The following is a description of a gene set: Absence (due to failure to form) or underdevelopment of the extremities. Human Gene Set: HP_APLASIA_HYPOPLASIA_OF_THE_EXTREMITIES studied in species Homo sapiens Aplasia/hypoplasia of the extremities, and this is the list of marker genes: POR, DACT1, KDM6A, WRN (NCBI Gene Id 7486), ARX, CRKL, PRKG2, KAT6B, SMARCB1, FBXO11, CANT1, HOXA13, BMP2, DMXL2, MGP, COG1, FANCE, ERCC4, SLC35C1, GRM7, RIPK4, GJB6, KDM5C, MTHFS, IFT43, EIF2AK3, PORCN, CAMK2G, TRAPPC2, DPH1, RB1, NGLY1, MED12, SMARCD1, STAMBP, RYR3, SLC31A1, MATN3, GMNN, CUL7, WASF1, PIGL, SNRPB, MEGF8, UBE4B, PIK3R1, TPR, KAT6A, ORC4, COL9A1, HDAC8, ZMIZ1, PLCB3, ANKRD11, EBP, PCNT (NCBI Gene Id 9346), DNMT3A, ZBTB20, SMAD4, UBR7, FBN1, USP9X, PDE3A, DNA2, AMER1, IHH, EZH2, CLTCL1, EN1, MEG3, CDK10, GAD1, CFAP410 (cilia and flagella associated protein 410), ADAMTS2, PDGFRB, SRY, IGF2, CRTAP, MMP9, EOGT, REV3L, SLC6A17, IL7R, SHOX, RERE, KCNAB2, FRAS1 (NCBI Gene Id 84949), PCGF2, DYRK1A, APC, B2M, RNF2, KIF15, CNOT2, MAP3K20, AGPS, CSGALNACT1 (chondroitin sulfate N-acetylgalactosaminyltransferase 1), GPC4, RPL10, CHRNA1, EFNB1, CAMTA1, ARL6IP6, BPNT2, HMGA2 (high mobility group AT-hook 2, NCBI Gene Id 8091), HHAT, DPYD, CDKN1C, TBCE, CLPB, CCNQ, DYNC2I1, RPS27, CCDC28B, WNT5A, DYNC2LI1, GRIP1, RAD51C, HESX1, CAMK2A, CDT1, FKBP10 (NCBI Gene Id 60681), PPM1D, ALG9, SLC25A24, SCUBE3, FN1, DOCK6, IRX5, SIN3A, TNNT3, NSUN2, PUF60, PPIB, CHRND, PRIM1, ASCC3 (activating signal cointegrator 1 complex subunit 3), PIGV, TRPV6, PIGS, STXBP1, ALG13, FANCD2, INTU, AMMECR1, NDN, COMP, KIF22, PTDSS1, RMRP, ROR2, CCDC22 (NCBI Gene Id 28952), FREM2, RSPO2, EIF4A2, COL10A1 (collagen type X alpha 1 chain), WNT7A, COL2A1, ARL6, SOX9, IFT52 (NCBI Gene Id 51098), FAM50A, EXTL3, PIGW, TRIP11, IFT172, ACVR1, TNFRSF11B, PIGG (phosphatidylinositol glycan anchor biosynthesis class G (EMM blood group)), SHH, TBCK, COL25A1, SPECC1L, ADAMTSL2, CCN6, CCN2, SH3PXD2B, FGF16, AFF4, SLC25A22, GABBR2, FBXO28, ORC1, MYH3, SOX11, KCNH1, SMARCA4, ARID1A, HTT, CNOT3, BPTF, RPL27, GNAS, BRD4, CENPE, FANCM, FZD2, PIK3C2A, NEPRO, EVC2, DLX6, SON, RECQL4 (NCBI Gene Id 9401), MBTPS1, ESCO2, LTBP2, UBE2T (NCBI Gene Id 29089), CTCF, USP7, HEATR3, PIGN, FGF10, CHRNG, COL1A2, CTNND2, IKBKG, PIGY, RAB33B, PRDM16, LONP1, HERC2, FLNA, RBM8A, FGFRL1, ATP6V1B2, PRMT7, DYNC2H1, PAM16, TMEM67, MIA3 (MIA SH3 domain ER export factor 3), RPS26, EXT1, ACTB, RBM10, CPLANE1, TRPV4, EIF4A3, TAPT1, ARCN1, LMBR1, GLI1, PIGA, CEP57, DLX5, MRPS28, IFT140, CWC27, PRKACA, FBXW4, FAT4, FLI1, OFD1, CHUK, LMNA (NCBI Gene Id 7816), UBE2A, DDR2, HINT1 (NCBI Gene Id 3094), GPX4, GNAO1, SEMA5A, CTC1, PPOX, KNSTRN, SLC39A8, SMARCC2 (NCBI Gene Id 6601), RBBP8, RPS7, ZNF407, JAG1, ADAMTS10, MIR140, NSDHL, GNPNAT1 (NCBI Gene Id 64841), PRKACB, NEK1, PIGF, LIG4, TCTN3, PLXND1, TGDS, PSMD12, FGD1, ZSWIM6, MEIS2, RPL11, CHST3, LZTFL1, PWAR1 (Prader Willi/Angelman region RNA 1), BICRA, MAB21L2, WNT10B, FANCC, ZMPSTE24, SF3B4, PDHA1, IFT57, DPH2, CCDC8, NANS, ALG6, PCYT1A, SKI, INPPL1, FTSJ1, RAG1, KYNU, KCNJ2, IDH1, DHODH, TBX15, GJA1, CRIPT, WDR19, SMOC1, TCF4, POC1A, NPAP1, PHF6, CDC6, MKRN3, ASXL2, ACAN, COL1A1, TRIM8, RPS24, PGAP2, HNRNPR, RAI1, ADNP, HUWE1, ATP7A, SETBP1, CTBP1, KIAA0753, RPL8, CEP120, RUNX2, PEX7, PTCH1, LUZP1, MAPK1, SMO, ZNF699, FANCA, RPL15, GSC, RAB34, PRKAR1A, DONSON, WAC, MASP1, KIF21A, IDUA, TRPS1, EXT2, PHOX2A, CPLX1, H4C3, CDKL5, CDC45, SMC1A, ERF, LHX4, NHS, CHD4 (chromodomain helicase DNA binding protein 4), SIL1, SLC39A13, TP63, PHYH, LIFR, ARHGAP31, IFT80, CHN1, MAPRE2, RPS29, RAC1, EBF3, MECP2, CUL4B, CHST11, GNA11, CREB3L1, DLK1, GPC6, KMT2A, BTRC, TELO2, MTOR, MECOM, CDC42BPB, CREBBP (CREB binding protein), TUBB3, TFAP2B, ACBD6, PIGT, LTBP3, HRAS, GNB2, SCN2A, TUBB2B, RPS6KA3, IFT81, NKX2-6, RSPRY1, SATB1, PUM1 (NCBI Gene Id 9698), FANCG, MTFMT, KLHL15, BMPR1B, CASK, GLI3, HDAC4, TBL1XR1, PTHLH, MAFB, SMARCE1, TBC1D24, YY1AP1, ANTXR2, KDM1A, AP1G1, NFIX, WDR81, TRAF3IP1, RAG2, SALL4, SCN1B, FLNB, TRRAP, ABCA12, COL11A2, BCR, ABCC9, CERT1, SLC35D1, IGF1R, PNKP, FAM20C, CILK1 (NCBI Gene Id 51541), CTSK, GNPAT, BMP4, DCLRE1C, TSR2, TWIST1, SIK1, TBX1, AIFM1, NTNG1, MMP23B, NPR2, FGFR3, TRPM3, ACP5, GHR, COL3A1 (NCBI Gene Id 1281), KCNA1, DLL4 (delta like canonical Notch ligand 4), XYLT1, VAC14, SLX4, VPS35L, MIR17HG, DYNC1H1, EDA2R, B3GAT3, DCHS1, DVL1, GNAS-AS1, ASPH, IFNGR1, ROBO1, IDH2, EDA (ectodysplasin A), ACTL6B (actin like 6B), PIGO, MMP13, GGCX, DDRGK1, HBA2 (NCBI Gene Id 3040), TUBA1A, SPART, ARID2, TPM2, FGFR2, DPM1, RTL1, BRCA2, BCOR, HEPHL1, TBX22, RPS17, SALL1, CHSY1, KIF7, RPS20, ALPL (alkaline phosphatase, biomineralization associated), B3GALT6, PEX5, RNU4ATAC, PRG4, PDE4D, LAMA5, BGN, NOG, LMX1B, ASXL1, MAP3K7, SLC26A2, GRIN1, TGFB1, ALMS1, ANAPC1, ALDH18A1, POP1, ASAH1, NOTCH1, FANCI, SOX4, RAB23, FMR1, WLS, CASZ1, POLR3A, CACNA2D1, FUT8, TBX5, PKDCC, PALB2, NEUROD2, CRELD1, TFAP2A, PTH1R, OBSL1, XRCC4, CDH11, SVBP, TTC21B, P3H1, EVC, DHCR24, FGF9, MAD2L2 (NCBI Gene Id 10459), RPS28, GATA1, KMT2D, TRIO, ADAMTS17, DPF2, SLC10A7, BBS1, LMNB2, POLA1, RPL9 (ribosomal protein L9), PRKCZ, SLC35A2, HSPG2, FIG4, TNFRSF11A, CSPP1, PIGQ, B3GLCT, CUL3, C12orf57, FBXL3, COL9A3, NSD2, ADA2, SIM1, COL9A2, ARID1B, PIK3CD, AFF3, KCNN3, ATR, CCDC47, IQCE, GLB1, NIN (ninein), CHD7, CLCN7, CD96, TAF6, MAPK8IP3, KCNJ8, MCTP2, PLAG1, RAD21, FANCB, MTX2, ZFX, SNRPN, SLC32A1, BRIP1, ARSL, GPC3, ITPR1, ZIC3, GABRD, WDR35, UBAP2L, SPEN, ALOXE3, PPP2R3C, SERPINH1, BHLHA9, NALCN (NCBI Gene Id 93074), RPS15A, PHGDH, B9D1, COG4 (component of oligomeric golgi complex 4), LHX3, PDPN, TONSL, MAGEL2, VPS13B, KIF5C, RPS10, POLE, MET, TWIST2, GNPTAB, SNIP1, SUCLG1, HDAC6, ADA, EP300, DHCR7, HBA1, RPL5, SMC3, IFT122, NXN, FGFR1, GLUL, CEP152, RFWD3, PGAP3, KIAA0586, MYSM1, CBFB, GJA5, TMEM53, RAB3GAP2, SNORD115-1, EPS15L1, GJA8, DYM, SRCAP, GJB2, FANCF, BRCA1, CLDN16, ZMYM2, FANCL, NIPBL, HPGD, MBD5, ALOX12B, RPL26, CRLF1, MBTPS2, GDF5, UNC80, KDM4B, OCA2, COX4I1, SMARCA2, ALG12, IL2RG, RAD51, GALNT2, DVL3, WNT3 (Wnt family member 3), NBAS, LBR, POU1F1 (POU class 1 homeobox 1), SCARF2, SLCO2A1, WIPI2, PITX1, BRF1, SATB2, RPL35, TBX3, ERI1, PIGP, LAS1L, FERMT1, KIFBP, STX16, NOTCH2, PIGB, XRCC2, COL11A1, RPS19, WDR26, KCNJ5, HOXD13, DYNC2I2, LRP4 (LDL receptor related protein 4), FBXL4, RBPJ, RPL18, ORC6, MSL3, TNNI2, SIK3, KRAS, MYCN, RPL35A, LETM1, HYLS1, EXOC6B, RPL31, AHDC1, PAPSS2, SEM1, NELFA, SNORD116-1, MACROH2A1, CHD6, PWRN1, TBX4, PROP1, CCBE1 (collagen and calcium binding EGF domains 1)